The following is a description of a gene set: Episodic flaccid weakness Human Gene Set: HP_EPISODIC_FLACCID_WEAKNESS Recurrent episodes of muscle flaccidity, a type of paralysis in which a muscle becomes soft and yields to passive stretching. species: Homo sapiens, and this is the list of marker genes: KCNJ2, SCN4A, CACNA1S, GABRA3, KCNE3, KCNJ5, KCNJ18